Given this list of marker genes KAT6B, STPG1, MMUT, ORC6 (origin recognition complex subunit 6), C12orf60, FBXW5, TMEM242-DT, HIPK1-AS1, C12orf76, ZNF493, TMTC4, MLST8, DIS3, TECPR1, RWDD1, GPR180, ZFHX3-AS1, ZMYM2, ITFG2-AS1, TFPT, ISOC2, FAHD1, MED23, ZNF695, MAP3K9, BRF2, LPXN, FXN, RSPRY1, CCDC12, CDC25A, ZNF830, ANKHD1, SLX9, ACTMAP, RAB11B, SLC25A3, TROAP, DNM2, SRP9, GOT1-DT, HSPA5, POLR2A, PPP2R1A, NEAT1, PRMT1, LSM5, TSTD2, MEAK7, ZFYVE21, GTF2H4, CHD8, TRMU, PNKP, RBM42, STK11, ZNF91, TMEM38A, ALKBH6, MAGI3, SNRPA, COPE, MTFR2, ZNF652-AS1, KAT14, SIVA1, IFT56, TEPSIN, BBS12, TXNDC16, DHCR7, DCTN5, RRAGC, PEX14, SGTA, MATCAP1, FRYL, PSMC3IP, ZFP91-CNTF, IER5L-AS1, FAM111B, FAM72B, PRKACA, ZNF77, PIK3R2, DNAJB5, ZNF726, KCTD9, ITGA5, MIR4479, CPSF4 (cleavage and polyadenylation specific factor 4), THUMPD3-AS1, NEURL2, ENPP3, ENSG00000232995, SHPK, CHCHD3, MTMR12, IFT27, NUP107, KMT5A, KDM4D, RPTOR, PPM1K-DT, ZNF324B, ZNF418, AKTIP, NUDT16-DT, KIF22, ZC2HC1C, CEP89, RNVU1-2A, GLO1, TRIM9, SNAPC4, TRMT10C, TMEM203, TRAIP (TRAF interacting protein), ROGDI, NAIF1, C19orf53, WBP1L, H2AX, LENG8-AS1, SCRIB (scribble planar cell polarity protein), ANKRD54, ANAPC15, XPO1, NABP2, SEC13, ACAP2, FAM53C, MAP4, MVD, NMNAT1, BLM, DCBLD2, PBX4, EMC3, RPL18A, RBM4, C14orf93, CLUHP3, ENSG00000275740 (NCBI Gene Id 127814297), TSNAX, R3HDM1, LAMTOR4, ATF7, TYW1, TP53BP1, LCMT1-AS1, SNHG10, MRPS31P4, KAT7, RPS27P14, ATP6AP2, UBXN6, SNORD60, ZNF143-AS1, TMEM179B, RANBP6, CENPU, TPCN1, TOR1A, PNPO, LINC02926, PANK2, ANKRD11, JUP, FBXO24, CKS1B, DUS2, RGMB-AS1, ZNF85, ALKBH5, DCUN1D4, AURKA, COPS4, HLTF, DCLRE1B, PSMF1, YIPF2, ACOT8, LIAS, ARVCF, VWA7, GPBP1L1, DCTN6, GINS3, OXSR1, RBM28, EXOSC3, BAIAP3, MSMO1, MAP3K9-DT, STX5-DT, TAOK3, SELENOO, MDM1, CDIPT, BRPF3, MAST1, FKBPL, KDM4B, ATP6AP1, ZBTB4, SSR1, SARNP, BLOC1S3, ZNF721 (zinc finger protein 721), KDM8, TPT1P15, MYH9-DT, GRPEL1, GSTCD, PABPN1, SPC24, CAMTA1, ONECUT2, DIAPH3, HSPB6, ZNF519, SLC25A44, LLGL1, CGGBP1, TMEM41A (NCBI Gene Id 90407), RNU2-17P, MPV17L2 (MPV17 mitochondrial inner membrane protein like 2), GINS2, ZNF724, ARHGAP19-SLIT1, ZNF460, RAB5B, TMEM9, XRCC4, ZDHHC6, DNAJC14, ERCC2, ZNF564, IPO4, TSNAX-DISC1, CCHCR1, TRAF2, PIN1, TMEM184C, PIKFYVE, NUDT16, C7orf50, DGCR8, HEATR5A, IPO11, C5orf34, SNORA16A, ARID1A, MAP3K7, ZNF563, KDM6A, MED19, ALG11, MCAT, CCAR2, RPS15A, SLC25A28, PTBP1, ACTL6A, RBM14-RBM4, DPH7, CEP44, RPS20, AIRIM, RAB8A, PDIA6, SPG7, ABCA7, TIMM8B, PLCL1, COQ8B, KMT5C, PPFIBP1, NFYC, DDX24 (DEAD-box helicase 24), ZFP91, PDP2, TMX2, CREBRF, ASAP3, STARD7, POLQ, MTOR, PURB, FICD, METTL25, ALG1, P4HB, CEP131, HEATR5A-DT, XRCC3, ATP8B3, RNVU1-14 (RNA, variant U1 small nuclear 14), FGD6, LINC01972, B4GALT7, SPSB3, PCNX3, NFYB, EXOC2, TIMMDC1, DROSHA, NUBP2, ZNF213-AS1, DPP3, CEP68, SAP30BP, ZNF587B, FAR1-IT1, SLC1A5, MLLT1, PRR11, SUPV3L1, ANP32E, HTT, CENPA, VEZT, KBTBD4, GRK6, PPP2R5A, C10orf88 (NCBI Gene Id 80007), FAM161A, FAM120AOS, MANBAL (NCBI Gene Id 63905), LIPE-AS1, PDIA4, APLP2, HELQ, WBP11, GBA1, LZTFL1, KLF5, G3BP1, TRAF7, TRABD-AS1, ZRANB3, ATR, MAP3K11, BAZ1B, ZNF273, NME1-NME2, KCTD7, NUF2, UBP1, STAT3, TDRKH, DRAP1, MECP2 (NCBI Gene Id 8274), SHARPIN, LINC01572, CDC23, MIR4727, WHAMM, S100PBP, VPS13D, DDX56, CSTF1, USP5, SLC25A28-DT, HDGFL2, RSRC1, GSTO2, SSBP1, ZSCAN32, ARFGAP1, TMEM218, UVRAG, DAPK3, AARS1, PPP3CA, MRPS16 (NCBI Gene Id 64959), SPRYD3, KHDRBS2, MRPL46, RAB11A, CEBPG, HSF2, HDAC6, MRPS23, ZDHHC12-DT, BMS1, CCDC159, HSD17B12, CDKAL1 (CDK5 regulatory subunit associated protein 1 like 1), FBXL6, SARS2, PPP1R12C, SLC35F2, TMEM53, ENO1, AP3M2, GHITM, NUDT21, URB2, ATG16L1, ZNF213, ZNF774, SOS1, SNAI3-AS1, ENSG00000267698, ANKHD1-DT, VCP, MIEF2, GTF2IP12, TSPAN31, UGP2, SZT2, SCAND2P, PSMD3, NDUFAF1, EIF1AD, GOLPH3L, NCBP1 (NCBI Gene Id 4686), RRP15, C9orf85, TRIM45, SMG8, HDAC4, CTNS, ADAT2, SRP14, MIR4449 (microRNA 4449), CIZ1, NGDN, SLC46A3, NARF-AS2, LINC02777, MYH10, MYCBP, WEE2-AS1, CENPK, TCERG1 (NCBI Gene Id 10915), ZDHHC9, CHCHD7, WDR81, GOLGB1, MAPKAPK5-AS1 (MAPKAPK5 antisense RNA 1), ESF1, C2CD5, BPGM, ZNF597, NLK, SNHG19, CDCA8, ZNF718 (zinc finger protein 718), MIIP, RPIA, POLRMT, CYB5B, HRAS, CREB3L3, VPS4B, ATP5MC1, ZNF776, DNAJB4, TTBK2, FAM98C, SLC25A19, TMUB2, NOL6 (NCBI Gene Id 65083), CWF19L1, CIDECP1, TBC1D19, MPZL1, ZNF599, ARSK, TSR1, TMEM60, DCTN4, RAB40C, TIMM29, CHCHD2, RMI2, PPP1R3F, RFX2, TBC1D22A, USF3, CDR2, PYCR2, ZNF132-DT, ARL17B, RPL38, ZNF419, DCTPP1, MRPL44, NR1H2, NR2C2, FBH1, SERTAD2, RAD18, HIRA, TYW1B (NCBI Gene Id 442576), PRPF31, NDUFA11, WIPI1, IQCD, ZNF773, RAB11B-AS1, PACSIN2, SWSAP1, ORC2, HSPE1, SP2, FAM220A, ATP7B, MYG1, SNX12, RPLP0, SNORD59A, VAMP4, KHSRP, ZNF772, CNOT1, ZSCAN20, TMEM205 (NCBI Gene Id 90585), TRMT1, RTRAF, NRL, ZNF277, SEL1L, HYCC1, ZNF548, COPZ1, NPLOC4, LINC02210-CRHR1, MROH1 (NCBI Gene Id 84500), DDA1, TICRR, ATP5IF1, GOSR2, HBP1, XAB2, HNRNPK, KCTD5, TCF3, UFD1-AS1, PPP2R5E, POLM, VRK1, CCDC15, RBMX, ANKRD39, SNRNP25, CHD6, IFI27L1, TPK1, SNRPC, NFATC2IP, DCAF15, FAM156A, C12orf57, PEX16, HDGF (heparin binding growth factor), ZC3H6, SLC26A2, RARS2, AIMP2, ZNF555, OXLD1, SNRPD2, OSBPL2, APMAP, MCM3, GLTC1, CYTH2, FGD5-AS1, GID4, TESK2, ECD, HTT-AS, WDR24 (WD repeat domain 24), SRGAP2, CCNG1, CBX5, TEDC1, MED7, ZNF584, ZNHIT3, FAAP24, MRPL21, RPUSD3, OTUB2, RAB5C (NCBI Gene Id 5878), CIT, PEX1, SETD5, WASHC3, RELCH, TMEM199, AIDA, SAP30L-AS1, ZNF460-AS1, GOLIM4, ZNRD2, TARBP2, RNVU1-4, CCT8, DDX49, PSMB7, UMPS, ENSA, FANCI, EPM2AIP1, SRP14-DT, PSMB3, NIPAL3, ACTR2, MXD1, AP4B1, CLIC1, HSPD1, ECSIT, EIF2AK3, TNFRSF10B, CROT, PALB2, DOLPP1, NDUFS7 (NCBI Gene Id 4727, NADH:ubiquinone oxidoreductase core subunit S7), ZNF691, ZNF691-DT, GLRX5, RFX1, ZMPSTE24-DT, ATG4B, MCU, OGFOD1, MCM6, AP2A1, HGS, ZNF138, NDUFAF5, PRDM4, ZIK1 (zinc finger protein interacting with K protein 1), ADGRL1-AS1, RBSN, SUMF1, ENSG00000261335, POLR1D, EIF2B1, NUFIP2, MRTFA, JPT1, SAMD4B, MIR4482, TOP2A (DNA topoisomerase II alpha), TOP3B, CDCA2, TOP2B, SYT5, PDXP, PPP6R3, RMI1, AGPAT1, HNRNPR, LMBR1L, ADAP2, PANK2-AS1, PSTK, EIF2B2, CREB3L2, FNBP4 (NCBI Gene Id 23360), TTC21A, AGFG2, CCNA2, ABHD2, ZFP41, DERL2, CCT6B, PGAP2, SDF2L1, GATC, YBX1, ZNF141, ABR, TRIP4, TSR3, BABAM1, DHCR7-DT, CNPY2-AS1, DCAF4, MAPK8IP3, RRBP1, MYL11, RFWD3, RAB4B-EGLN2, BMAL1, EIF1 (NCBI Gene Id 1963), PTCD1, ANKZF1, GNPTG, ISG20L2, CERNA3, EPOR, MRPS15, PER1, MIS12, COX19, PDCD11, RNFT2, HCCS, CS, ITGAE, EHBP1, ENSG00000275765, ZNF407, LENG8, EEIG1, HEXD, GYS1, RAB39A, NUDT2, MED4, EIF3F, INO80, LINC00205, LINC01003, HNRNPL, BCL2L1, ZNF417, FHIT, CNDP1, TCEA1, GRIK4, RBIS, SNRNP40, LSM11, POMT1, CWC25, LACTB, CLDND1, MTR, FAN1, SNRPA1, CFAP20, SPRING1, STK40, MRPL37, LMTK2, DCAF11, NFE2L1, SNORA26, CTSA, CARF, PIBF1, EIF4A1, HSPA5-DT, GOT1, ANKHD1-EIF4EBP3, CD101-AS1, RCN2, MIS18A, ZNF574, ARL16, NCK1-DT, SIN3A, SLC2A8, CAMTA1-DT, G6PD, MCEE, TMEM160 (transmembrane protein 160), HMGXB4, MAP3K12, LSP1, QPCTL, IDH1, TCF19, PLIN3, CYB5A, CDCA3 (cell division cycle associated 3), MRPS12, LENG1 (NCBI Gene Id 79165), GMFG, NKTR, C22orf39, WDR6, BRPF3-AS1, PCF11, CCNF, NDOR1, E2F1, TANGO2, IP6K1, SCP2, MIR3181, PLPBP, DPP3-DT, TRIP10, IK, YJU2, TXNL4B, KLHDC10, CCNL2, DZANK1, GLCCI1, ZNF654, HEXA, MORC2, RNF187, CNOT3, DNAJC11, CRYZL1, HAPSTR1, FAM72A, CHAF1A, SFSWAP, FDFT1, ZNF132, SEMA4F, ZNF595, HDAC4-AS1, PCYOX1L, ZCCHC17, AKR1D1, ATF6B, ARMH1, PHTF2, GANAB, MRPL3, HIPK1, CDC25C, DNM1, ATG14, FAM76A, MACO1, INTS4, HERC3, ZSCAN5A-AS1, ING1, DCP1A, TRAFD1, SSNA1, FOXK2, LRP12, GORASP1, TIMM44, GET3, AKAP8, FRMD5, TOM1L2, IL6ST, CWC15, ATP6V0A2, TRIM35, KHDC4, U2SURP (U2 snRNP associated SURP domain containing), SDHD, COX14, DYNC2I1, BRD3OS, CCT7, AQR, RTN4, HNRNPC, LIM2-AS1, SMARCA2, PHPT1, HDAC11-AS1, SLC27A4, ZNF805, ZNF736, IVD, NSMCE1-DT, H1-2, MBD1, TRMT44, EIF5, CTPS1, PMS2, OGFOD3, VPS28, VIRMA-DT, GPR137 (G protein-coupled receptor 137), SETD3, GPATCH3, NARF, ZNF143, PCGF1, SEC22C, RIF1, SSR3, SNX18, RRAGC-DT, LINC01409, BUD31, GOLGA3, DHX38, YIF1A, MINDY3, JPT2, LINC01535, PIGN, CHASERR, NDUFS8, TBCB, ENSG00000268129 (NCBI Gene Id 100293099), ZNF211, ZSWIM1, RNF4, ZNF547, ENSG00000255240, DPH2, CENPX, ERICH1, HS3ST3B1, OTUD5, RNF5, NBR1, VTI1A, RNU6-92P, MDH1B, STOML2, TCP1, NUP98, ZNF837, HASPIN, ZNF10, RTTN, MIR638, LMAN2, SFPQ, ZSWIM4, LRRC45, ZNF823, CYB5RL, RUVBL1, DACT3-AS1, RGMB, GNA12, MGRN1, TBL3, ZNF367, TMEM167A, PGD, ZMPSTE24, STX18, WDR53 (WD repeat domain 53), FER, SLC39A3, ADRM1, HMGCS1, VPS72, SRSF6, DANCR, DOCK4, MAF1, CEP164 (centrosomal protein 164), PXN-AS1, ENTPD7, RAF1, SKA2, PJA2, RHPN1-AS1, RHPN1, GRN, ASB16-AS1, EVI5L, EIF2D, CDK2AP2, PEX3, CRBN, STT3A, SNHG12, FAM149B1, POLDIP2, MVK, VIRMA (vir like m6A methyltransferase associated), PROSER3, MSH5, TRAPPC2B, ENSG00000254531, RIOK1, MAPT, BRIP1, ARRDC4, TRIAP1, TMEM198B, DDX41, MAP3K3, RPE, ZBTB5, PDXDC2P-NPIPB14P, CANX, NOM1, VPS35, DNAAF3, CNPY3, DENND4A, MRPS18C, C19orf81, LCA5, RGS9BP, KCNAB2, TTC9C, ARHGEF19, NAA60, SNX16, DBP, RPL37, HINT2, ERMARD (NCBI Gene Id 55780), GOSR2-DT, NOC3L, NUP107-DT, SLC25A42, FAM117A, LRRC47, PAAF1, NXT1, SPTLC2, ENSG00000255647, ZSCAN31, ATP5ME, ZNF174, SLC39A1, RPL13A, GLOD4, CARS2 (cysteinyl-tRNA synthetase 2, mitochondrial), PTK2B, TPRN, PKNOX1, ZMAT2, SPC25, SND1, ATP5MK, CIRBP, INIP, ETV5, ALKBH3, DDX55, CYLD, C18orf21P1, CETN3, TMEM134, TP53TG1, GLRX3, LCMT1, SF3A3, CA13, MOSPD3, HCCS-DT, YARS1, TSPAN15, ZBTB3 (zinc finger and BTB domain containing 3), RHCE, HMGN2P34, MIR4999, CREB3L4, TMEM191C, SLC4A1AP, UNG, DNAJB5-DT, ASF1B, MAPKAPK5 (MAPK activated protein kinase 5), SNRPB2, C8G, CCDC137, TIMM22, IFRD1, PEF1, CDKN3, FAM222B, PGP, GTPBP3, HINFP, RNU6-9, ZNF669, SCAI, PSMB10, SUPT7L, PSMA1, KPNB1-DT, MRPL39 (NCBI Gene Id 64977), KATNB1, NUDC, RAB4B, HAGH, MLH1, CETN4P, ABHD17B, SLC15A4, ZDHHC12 (zinc finger DHHC-type palmitoyltransferase 12), SKIC3 (NCBI Gene Id 9652), ABT1, PAFAH1B2, TMA7, VBP1, AKAP8L, TMPOP2, SP2-AS1, MTMR4, PXMP4, DEF8, MCM5, ALDH6A1, SNRPA1-DT, ARHGAP19, CROCCP2, FEM1C, MARCHF2 (membrane associated ring-CH-type finger 2), LARP4B, ENSG00000263080, ZNF584-DT, CCNC, RECQL5 (NCBI Gene Id 9400), SHC1, RNVU1-19, ORMDL2, ZNF407-AS1, JMJD8, MEX3C, HNRNPAB, PPM1B-DT, TAF3, HAVCR2, ZNF430 (zinc finger protein 430), PCLAF, DCAF7, ZNF44, EMG1, COA4 (cytochrome c oxidase assembly factor 4 homolog), GTPBP6, DCTN3, CCT6P1, ZNF543, FLYWCH2, AK2, ATP5MC2, DERL3, PSMA5, MRPS31, IDI1, GGCT, RAB3A, SEC1P, ZNF17, NKAIN4, ZNF687, GPR137C, CBLB, ELMO2, SMAD2, TMBIM4, LIN52, WDR45, KIF1B, PUM3, HNRNPUL1 (NCBI Gene Id 11100), CCDC146, NDUFA2, UBALD2, CDK11B, CPPED1, INTS5, TDRKH-AS1, MMAB, RCL1 (NCBI Gene Id 94533), NAGPA, AKT1S1, ACYP1, KDM3A, POLR3K, MTF1, SFXN5, ZNF672, GNE, NUP214, WDR37, MPHOSPH10, GPHN, STIP1, SUN2, KANSL2, MON1B, BRCA1 (NCBI Gene Id 672), ZMYM5, CLASP1, FASTKD2, OSBP, PWWP2A, BUB3, TMEM167B, RGS5, GATAD2B, OS9, PRADC1, TRIOBP, ZNF687-AS1, CAGE1, TIAM1, CDIPTOSP, DHODH, ZNF552, EARS2, SNORD54, NSMCE1, ENSG00000233461, CENPBD2P, PET100, SND1-DT, POLD2, METTL13, LRCH4, ALKBH7, ZBTB20, ITGB4, RPL9, ENSG00000239137, MAEA, MRPL16, HSPE1-MOB4, RBM48, RPS15, CENPQ, LTN1, INPP5B, MRPL18, SMIM7, COX8A, APTR, SP1, GTPBP1, MTIF2, TUBB4B, FBXO45, CCDC51, CIC, TEX2, ATP5PF, FLAD1 (NCBI Gene Id 80308), VARS2, ZNF652, ZNF101, UBFD1, VMAC, NUMB, RUVBL2 (NCBI Gene Id 10856), WDCP, GNG4, ITFG2, PDAP1, FANCD2, ATP5PD, C8orf33, DDX39A, WFS1, HEXA-AS1, H3-3B, THAP4, MRPL28, AP3D1, MST1P2, PIGM, IDH3B, DCTN6-DT, FAR1, ZNF354A, PCBP2, MED30, STX18-AS1, KPNB1, HIP1 (NCBI Gene Id 3092), RTN4R, PDXP-DT, ATP6AP1-DT, ZSCAN5A, HNRNPA1, LRRC74B, NF2, ANAPC2, ADSL, CDK5RAP3, TARS2, DYNLT2, ZNF200, ARMC6, ATPAF2, COMT, TMEM242, TRMT61B, PSME3IP1, TSPAN10, MSH5-SAPCD1, PPWD1, ZCCHC4, PAF1, RAD54L, BROX (NCBI Gene Id 148362), FAM32A, EMC9 (NCBI Gene Id 95655), RNU6-1310P, ANAPC5, INTS3, TPRG1L, LAPTM4A-DT, PLAG1, TOMM40, CRTC3-AS1, COMTD1, BAZ2A, MSANTD4, CDK5RAP1, RPS7, TSR2, DCP1B, H2AZ2, RNF34 (NCBI Gene Id 96268), TRIM68, ZNF100, HDAC11, P2RX6P, ANKRD23, RAB40B, ZNF891, PPM1B, RASSF7, ZNF775, PHF5A, TBC1D10B (TBC1 domain family member 10B), SLC25A25, ARL6IP6, ACOX3, MED8, ZNF431, EMC3-AS1, CAT, HACL1, GRPEL2-AS1, SEC11A, ENSG00000224905, TBC1D22A-DT, ORC3, C5orf22, TMEM69, PET117, SHKBP1, MED29, GTF3C5, RBM14, AAMP, DLGAP5, IL6ST-DT, SAP30L, ITK, COPG2, ENSG00000267248, TMBIM6, ACTG1, LNX2, MRPL20-AS1, MTERF4, ZNF556, H2AZ2-DT, ANKRD16, POLR2I, MIR22HG, GABPA, LIN37, TRAPPC6A, BBS10, CALU, FCGRT, PIN1-DT, ZNF581, PPM1K (NCBI Gene Id 152926), PHB2, MIR1302-3, PLLP, LRRC27, ZNF250, MRPL4, EIF2AK3-DT, GARNL3, PAIP2B, UBE2C, RBM27, AMBRA1, WBP1, COMMD2, GDI2, FAM227B, ABCA11P, NEMP1, COPS7B, NPHP4, SNX32, KCTD2, IDH3B-DT, YWHAQ, IBA57, BTD, BCAS3, NECTIN1, ZBTB18, NDUFAF8 (NADH:ubiquinone oxidoreductase complex assembly factor 8), ATF7-NPFF, ABCB8, GALNT18, MED16, HIBADH, MZF1, METTL15, NCOA2, WDR12, PRPF40A, TBC1D14, MTF2, CEP152, KANSL1, PEF1-AS1, C11orf68, IKZF4, DACT3, DDX19B, LINC02210, PPM1F, IGHMBP2, PPIA, GPR108, MIR6089, EML2, ST3GAL2, IRF4, CRTC2, BANF1, STX16, CDR2-DT, LINC01547, ACO2, ABHD8 (abhydrolase domain containing 8), ZNF57, CSE1L-DT, RAB3D, RPL22, MYL5, PNKD (NCBI Gene Id 87830), MANF, AKAP17A, RBM15, FAM185BP, OIP5-AS1, FH, POLR3F, GTF2H3, NFE2L1-DT, VPS33A, DPH1, COQ8A, TTLL5, ANKRD27, STX16-NPEPL1, RBM15-AS1, CEP85, EFNB2, ENO1-AS1, TAF5L, EIF2B3, FKBP5, ZFTRAF1, STOM, KANK3, ZNF550, VPS50, ESR2, ZNF443, TEFM, MYH9, PHYH, SPAG7, NR3C2, ATG9A, MCOLN1, PMEL, ZNF799, CENPM, SLF2, ZC3HC1, NOB1, TNRC6B, ITSN1, NDUFS3, TNRC6B-DT, DTWD1, ZNRD2-DT, ZNF165, DDOST, NCK1, CKAP2L, TYK2, LZIC, TIMMDC1-DT, LMNTD2, SAMTOR, ZNF626, SP3, DRC3, EDEM3, GTF3C3 (NCBI Gene Id 9330), YJU2B, SDHAF1, CCNK, MEGF9, ZNF416, VPS51, COPS3, MAN2C1, RSBN1L, INTS12, PKMYT1AR, RNU7-27P, MRPS11 (NCBI Gene Id 64963), ELAC2, FBRS, ATP5PBP7, IER5L, GBF1, NME1, GATB, SRGAP2C, SPATC1L, INCENP, CCDC61, MXD4, MRM3, SEPTIN7P14, ZSWIM3, DNAL4 (dynein axonemal light chain 4), GATAD2A, ATP5F1B, ZNF875, WIZ (WIZ zinc finger), EIF4B, PRPF8, PDE6D, TMEM184C-DT (TMEM184C divergent transcript), TTF2, CCDC59, COX16, SLC52A2, PSMD11, BRI3, TAF1C, TACO1 (NCBI Gene Id 51204), here is a description of the gene set: from publication Yevshin I, Sharipov R, Kolmykov S, Kondrakhin Y, Kolpakov F (PMID 30445619) Human Gene Set: CEBPZ_TARGET_GENES studied in species Homo sapiens Genes containing one or more binding sites for (CEBPZ) in their promoter regions (TSS -1000,+100 bp) as identified by GTRD version 20.06 ChIP-seq harmonization.